Given this list of marker genes Stk3, Bicra, Sav1, Nsd3, Mbtps2, Jmjd6, Hif1a, Elk1, Ddit3, Parp1, Notch1, here is a description of the gene set: species: Mus musculus A molecular function regulator that increases the activity of a transcription regulator via direct binding and/or post-translational modification. Mouse Gene Set: GOMF_TRANSCRIPTION_REGULATOR_ACTIVATOR_ACTIVITY